Given this list of marker genes CEP57, FGFR1, MGMT, VHL, ANKRD11, EYA1, PTDSS1, PTH1R, DACT1, KRT14, CDKN1C, TBXT, SYT1, PARN, B3GALT6, SMAD4, TBL2, ESCO2, NDUFB11, ATP7A, WRN, FKBP6, IRF6, FMR1, ALPL, NLRP1, LTV1, PORCN, TP53RK, EDN1, CPOX, STAMBP (NCBI Gene Id 10617), PRKCD, METTL27, FOXI3, ZMPSTE24, KIF1A, ITGB4, PYCR1, PAFAH1B1, KDM5C, LOX, KMT2D, CTNNB1, CHD6, COL6A3, ERCC5, SOX5, NOTCH2, SMPD1, SVBP, BCL6, KRT6A, KRT2, KCTD1, MSX1 (NCBI Gene Id 4487), FGD1, RETREG1, H4C9, GJB2, CHRNG, GLI2, ABL1, H4C3, WIPF1, SETD5, ADAMTSL2, ANKLE2, OTULIN, FBN1, ADAR, BRCA2, FANCC, P4HA2 (prolyl 4-hydroxylase subunit alpha 2), KCNAB2, POU2AF1, ODC1, CASZ1, SHOC2, DUT, PDPN, COL2A1, AQP5, SEC23B, SPTBN1, SPTLC1, SPRED1, HK1, USP8, BCOR, PTCH1, ZNF668, ANK1, XYLT1, SLC26A2, NXN, ZSWIM6, PTCH2, EED, PLP1, TWIST2 (twist family bHLH transcription factor 2), FGFRL1, DOCK6, ALX1, PSTPIP1, MAX, HPS1, DKC1 (NCBI Gene Id 1736), PUF60 (poly(U) binding splicing factor 60), USB1, MED13L, CAPN15, WRAP53, SLC2A10, CARD14, IRX5, AHDC1, GRB10, IDH2, CCDC22, TLR4, UBAC2, CREBBP, KLLN, SMOC1, CPLX1, ALX4, SKIC3, CAV1, ARF1, ARVCF, SMC3 (NCBI Gene Id 9126), POLR1B (RNA polymerase I subunit B), RBCK1, TOMM7, CCR6, THPO, WNT5A, RASA1, NAXE, TBX1, SDHC (NCBI Gene Id 6391), TGFBR1, IL12A-AS1, LAMB3, CDH11, BRCA1, GHR, SHANK3, TFAP2A, CTCF, PMVK, IPO8, DVL3, DCHS1, WNT10A, LPAR6, SALL1, TBX5, GATA1, SOX9, TNFRSF1A, HBB, CTC1, CUL4B, EFTUD2, KDR, THBS2, BCL2, DOCK8, PRDM10, EP300, ZFX, TAP1, PLAG1, LDLR, SLC19A1, GPC4, NCAPG2, UBA2, TNFSF15, ATL3, SUFU, SMAD3, MAP2K2, SPECC1L, SPTSSA, WDR1, GJB4, CDH1, NOTCH1, WLS, SPRED2, AEBP1, KLRC4, FUZ, PRKD1, TAF1, IL17RC, ERAP1, MAN2C1, BTK, KRAS, PGM3, CCL2, MAP2K1, MTAP, ABCG8, PRTN3, SATB2, MED12, COL6A1, CYLD (NCBI Gene Id 8010), GBE1, ECM1, VANGL1, LZTR1 (NCBI Gene Id 8216), CHST14, MEN1, SMC5, CYBC1, TCOF1, DDR2, CTNND2, ARFGEF2, XRCC2, SLF2, ZIC3, BUB3, FAT4, FZD2, ALK, POLR1A, IL36RN, TERF2IP, PERP, SLX4, ERCC6, GATA6, HEPACAM, TXNL4A, SETBP1, TSC2, H1-4, KDF1, ZFPM2, NAGA, HRAS, KANSL1, FUS, UBAP2L, PIGL, ORC1, SOX18, ARMC5, PIK3CA, TP53, KITLG, NOP10, LIPC, NHP2, SKIC2, FGFR2, SPOP, GNAI3, NR3C1, CTLA4, HIC1, EZH2, ALG9, SMARCA2, KRT1, PCGF2, SOS1, POFUT1, BLM, SDHD, FOCAD, MAPRE2, PUS3, MYH3, MAP1B (NCBI Gene Id 4131), STAG2, KCNQ1OT1, IARS2, DDX11, PTPN11, NTRK1, SLC29A3, GSN, KIF11, GRHL3, DHCR24 (NCBI Gene Id 9800), PTPN6, ALX3, HNRNPK, IKBKG, LEMD3 (LEM domain containing 3), CDK4, FANCF, SALL4, TERC, MSX2, APOB, B3GLCT, NSDHL, IL12A, DNAJC30, NOD2, TGM5 (transglutaminase 5), UBE2T, PLXND1, PHOX2B, TMCO1, DHX30 (NCBI Gene Id 22907), IL17F, UBE4B, CARMIL2, MAP3K7, BAZ1B, CDKN2B, USF3, CDH3, MLH1, IL17RA, PALB2, MMP1, STAT3, PCNT, PIGS, HLA-DPB1, PROS1, SUGCT, H4C5, CHN1, CLTRN, GATA5, NFKB1, HDAC8, POLD1 (DNA polymerase delta 1, catalytic subunit), PHIP, FLT4, GTF2IRD2, ZNF699, FANCA, GPIHBP1, CTNND1, CCR1, B2M, GNA11, MID1, DLG4, WASF1, CBL (Cbl proto-oncogene), FERMT1, ATRX, LAMC2, NKX2-6, MAD2L2 (NCBI Gene Id 10459), FANCG, KRT16, TCIRG1, IL23R, HOXA13, KMT2A, CAMK2A, EDARADD, SF3B2, PRKCZ, BMS1, CLCN7, LPIN2, SET, PPOX, MGP, NSD2 (NCBI Gene Id 7468), COL14A1, RHOA, HLA-DRB1, OCA2, TP63, MMP23B, CTBP1, ANTXR2, MED25, ERGIC1, NEK9, IFNGR1, ACP5, MEFV, DICER1, BGN, PMS2, MSH2, EIF4H, BUD23, TYMS, SMG9, SLURP1, PIGG, CDH23, WASHC5 (WASH complex subunit 5), USP9X, TMEM270, EFEMP1 (NCBI Gene Id 399564), UBR1, COL5A1, MBTPS2, ALDH18A1, ATM, KDM6A, TNXB, RFX7, FERMT3, HEXB, DHCR7, COL7A1, SPTA1, VANGL2, OCRL, HLA-DQB1 (major histocompatibility complex, class II, DQ beta 1), APC, BAP1, TMC6, ABCC9, VPS37D, WNK3, TRIM37, DCLRE1C, CD28, YWHAE, HLA-DPA1, MITF, LORICRIN, CDKN2A, LMNA, SCN9A (NCBI Gene Id 93955), RECQL4, RAF1, CDKN1A, UROS, DIS3L2, FLCN, POLR3A (NCBI Gene Id 11128), OTUD6B, UBE2A, DSP, KRT6B, PAX3, MTOR, PRKAR1A, ELOVL4, DDB2, UFD1, GYPC, APOA1, ST3GAL5, EOGT, NGF, DDIT3, MLX, ATP6V1B2, FGFR3, GLMN (glomulin, FKBP associated protein), EIF2AK3, ADA2, WBP11, RBPJ, GBA1, EPHB4, AP1S3, ERF, IL12B, FANCB, SOX10, RBBP8 (RB binding protein 8, endonuclease), SLC6A19, RECQL, PTEN, TASP1 (NCBI Gene Id 55617), NF1, IRF5, SLC45A2, BUB1B, COL12A1, DST, KIAA0319L, NBN, KAT6A, KRT5, ADAMTS2, SEMA5A, MMP14, COX7B, KIF15, ABCC6, PSENEN, AK2, KIF7 (kinesin family member 7), GFI1, CHUK, APOA5, NSMCE2, LAMA3, KDM1A (lysine demethylase 1A), ASXL2, ENPP1, HCCS, TSC1, ASXL1, TAF4, GABRD, FGF3, ATP2A2, LETM1, B4GALT7, CD96, SLC17A9, SF3B4, DPP9 (NCBI Gene Id 91039), RRAS2 (NCBI Gene Id 22800), SLC4A10, TNFRSF1B, ATP2C1, NCF1, RREB1, BICD2, HLA-B, STAT4, PIGH, TREX1, CYP26C1, PCSK9, FBXO11, TYRP1, GPR101, PPP1CB, DNAJC21, NAA10, RET, NRAS, ATL1, EPHX2, TMEM260, TNPO3, NEDD4L, NSUN2, CIB1, KRT10, MYCN, CCN2, LIMK1 (LIM domain kinase 1), SPIB, EDAR, CRIPT, F12, KRT17, FKBP10, SLC25A24, RFWD3, XPA, SASH1, LYST, SMO, SBF2, HNRNPU, TMEM127, SLC39A13, CYBB, PSAP, GATA4, NECTIN1, CSTA, LMO1, NOTCH3, GNAQ, EDN3, GNA14, GALC, NLRP3, IGF1, IL10, KCNJ2, SNRPN, IKZF1, CLIP2, TGFB3, SH3PXD2B, COL1A1, SIX5, GJA1, EXTL3 (NCBI Gene Id 2137), GGCX, LIG4, ZNRF3, BRF1, TERT, IL7, COLEC10, LIN28B, GJB6, ZNF462, POLA1, FANCL, PSMB8, SPEN, GLA, CHRNA7, JAG1, KCNQ1, SPTB, PDE11A, IGF2, IDS, ERMARD, SCARF2, ARL6IP6, ABCG5, TRPM3 (NCBI Gene Id 80036), LMF1, RERE (NCBI Gene Id 9642), POLH, PTPN22, FANCE, UBE3B, SMAD2, PDE4D, NCSTN, CDKN2C, STK11, EPB42, GP1BB, DYRK1A, NFIX, PDGFB, FLNA, ERCC8, ZNF469, TEK, C1S (complement C1s), MVK, FANCM, MNX1 (NCBI Gene Id 7987), DPAGT1, REV3L, VPS35L, PPP1R17, TNFRSF11A, MMEL1, MC1R (melanocortin 1 receptor), ROR2, HIRA, RAD51C, FOSL2, MAFB, GNB2, SMARCAL1, FN1, AIP, EDNRB, ELANE, DEAF1, PIK3R1, NADSYN1, KDSR, GORAB, LPL, GDF1, INSR, AAGAB, TRAF3IP2, MCTP2, ACD, ANAPC1, MMP2, CITED2, TBX4, PLCB4, HAVCR2, TRPV3, PEPD, DVL1, GJA5, PLEC, TUBB, GPC3, RIPK4, COL5A2, POLE, GTF2I, HMGA2, ABCA1, STX1A, GPNMB, DLL4, C4A, BTNL2, SOS2, C1R, RAB23, HSPA9, ERCC3, IFT140, LDHA, LDLRAP1, MYSM1, IRF1, FKBP14, TINF2, SLC39A4, ACTB (NCBI Gene Id 60), RMRP, JMJD1C, TGFB2, MSL3, IDH1, RNU4-2, CWC27, COL6A2, FANCD2, ITGB2, CAMK2G (NCBI Gene Id 818), MAD1L1, EPB41, KLHL24, NKX2-5, LRP1, KCNK9, PLOD1, ATIC, DSC3, XYLT2, TCF4, UROD, RIT1, PDGFRB, BPTF, ELN, APOE, STEAP3, SPTLC2, POLR1C, PRR12, CHD7 (chromodomain helicase DNA binding protein 7), ITGA6, NCF2, RFC2, KIF1B, ASAH1, BLOC1S5, LUZP1, AIRE (NCBI Gene Id 326), ERCC4, LSS, SRP19, RPL10, EDEM3, TOP3A, DHPS, H19, RAP1B, PRMT7, ERI1, SDHB, POLR1D, RBM28, SCYL2, G6PC1, MASP1, ADNP, KIT, EGFR, PIGN, CCT5, VPS13B, PPARG, MRAS, ANTXR1, TMC8, BRAF, TMTC3, EDNRA, MPV17, WNK1, MPL, DSTYK, GSC, CAPRIN1, HSPG2, FANCI, TGFBR2, CHD8, MPDU1 (NCBI Gene Id 9526), PIGA, ADAM10, COL1A2, HEATR3, ARHGAP31, OFD1, EIF2AK4, CYP27A1, UBA1, MAPK1, TYR, USP48, LIFR, ZEB2, RRAS, AFF3, ARID1B, COPB1, CDK13, RBM8A, POMP, BRIP1 (BRCA1 interacting helicase 1), SUZ12, ERCC2, EXT2, PROC (protein C, inactivator of coagulation factors Va and VIIIa), POGLUT1, LIPH, COL17A1, SEC24C, CFTR, WAS (NCBI Gene Id 7454), APOA2, IL12RB1, FLNB, ERCC1, COMT, RAD51, SLC4A1, GJB3, CYBA, IL6, POT1, KDM6B, NONO, RTEL1 (regulator of telomere elongation helicase 1), CDC42, CRELD1, XPC, SLC9A1, IFNG, PAX1, BUB1, NELFA, TTPA, SLC37A4, COL25A1, NF2, CDK10, TRAF6 (TNF receptor associated factor 6), CLPB, AKT1 (NCBI Gene Id 207), SNAI2, GLS, PSMD12, ABCB6, ACVR1, CDKN1B, SIX1, SLC35C1, TRPM4, SEMA3E, EBP, LRP5, MAN1B1, MSH6, APOC2, HACE1 (NCBI Gene Id 57531), CLDN1, TRIP13, DPYSL5, KRT83 (keratin 83), LBR, NPM1, FAS, MDM2, AUTS2, COL3A1, SMARCAD1, B9D2, SKI, NPHP3, GTF2IRD1, RASA2, DSE, SYK, GNAS, CLEC7A, EDA, CTSC (cathepsin C), FRA10AC1, TNFRSF11B (TNF receptor superfamily member 11b), NCF4, PRDM16, here is a description of the gene set: A lesion of the skin that is located in a specific region rather than being generalized. Human Gene Set: HP_LOCALIZED_SKIN_LESION Localized skin lesion studied in species Homo sapiens